Given this list of marker genes THAP2, OTUD4 (OTU deubiquitinase 4), CYTH3, ADAMTS3, SRI, PRKG1, TENT4B, MBOAT2, DNAJB5, DNAJB9, HIPK3, UBE2W, ZNF224, CFL2, ANKRD40, LIN7A, HS3ST3A1 (NCBI Gene Id 9955), SEC23A, ZC3H4, KHDRBS1, ATP5F1B, CNEP1R1, QKI, VAT1L, LBR, SGCE, RO60, LRP1, PPP1R18, PTBP3, PITPNM3, CBX4, MAPK7, CASZ1, PTPN14, MED13, GXYLT1, FEZ2, NOVA1, TOB1, RANBP9, HIPK1, STRADB, ULK2, KIF14, GABBR2, SECISBP2L, CHSY1, DENND5B, BNC2, NR3C1, IMMP2L, SCN5A, ZFX, AGFG1, PRDM16, DCBLD2, SLC25A36, XKR4, CBL, YPEL2, ELOC, TRMT9B, PIK3CA, BDP1, ELL2, RUSC2, ERRFI1 (ERBB receptor feedback inhibitor 1), SLC24A4, PTAR1, CLASP2, ARIH1, RBFOX2, HOOK1, TFAP2A, SDC2, GJC1, GOLGA7, GATA4, SLC4A7, ZC3H6, SLF2, RBFOX3, INSM2, RBSN, GSTA4, FRMD6, MBNL3, CDYL2, RGL1, BCL11B, ITGA1, RDH10, ADH1B, PI4K2B, PCDH19, NOVA2, ANKRD44, TMX4, BAP1, NAB1, TRIM23, MSL2, PSAT1, NAP1L5, YWHAB, FSCN1, HSPA13 (heat shock protein family A (Hsp70) member 13), PTPN21, ATAD2B, S100PBP, CEP97, TBK1, RAB21, SLC6A11, TRAPPC8 (trafficking protein particle complex subunit 8), ERG, MMD, SUZ12, EGLN1, PPHLN1, GPRASP2, ATXN1, PHTF2, GNAQ, TLCD5, CAMSAP2, ALDH1A1, TRHDE (NCBI Gene Id 29953), NTRK2, RND3, EDEM3 (ER degradation enhancing alpha-mannosidase like protein 3), PMAIP1, MAP4K4, SFXN1, ETS1, GIT2, NCOA2, OSBPL11 (oxysterol binding protein like 11), NCS1, PPP2R5E, TBC1D12, ZYG11B, FOXG1, FLII, CLIC4, SCAMP1, USP25, PLPP3, NUDT4, LRP1B, INTS8, CRTAP, TBCA, CYTH1, ADIPOR2, SMARCD1 (NCBI Gene Id 6602), SYNJ1, APOO, TOGARAM1, AP1S2, PTPN12, CPED1, CRH, LOX, ERICH4, OSTM1, DESI1, MARCKS, PHF21B, HS3ST1, RTKN2, CDK17, JAKMIP2, JCAD, B3GLCT, ATP11C, PRTG, HYCC2, PUM2, CCNJ, PIM2, ZMAT3, SLC1A2, ZFPM2, WASF3, EXD2, MPRIP, SLIT2, ZEB1, COPS8, VEGFA, GARRE1, THAP1, ELAVL2, MAP4K5, PAG1, PROK2, TMOD3, HDHD2 (NCBI Gene Id 84064), SLITRK1, RAB11FIP2, DCUN1D5, AMFR, TAF12, PPP4R2, GOLGA1, CEP350 (NCBI Gene Id 9857), NRG1, JAZF1, SLC30A7, ARID4B, SCD, NTF3, FN1, TSC22D2, TAP2, CORO1C, FOXN2, GPR158, RIMS2, CTDSPL2, SLC35E2B, SULF1, EIF4E2, PPM1F, DNAJC3, SCAI, PIKFYVE, NPC1, POLK, NEDD1, SPAG9, STRN, MINDY2, CHN2, DPY19L3, CCNYL1 (cyclin Y like 1), MIEF1, DPH6, PKIA, PPFIA1, GLI3, PPP2R1B, FARP1 (FERM, ARH/RhoGEF and pleckstrin domain protein 1), STK4, TMEM164, ARHGAP6, BLCAP (BLCAP apoptosis inducing factor), SYDE1 (synapse defective Rho GTPase homolog 1), NUFIP2, DLC1 (DLC1 Rho GTPase activating protein), CHRDL1 (chordin like 1), MOSMO, LHFPL6, RIC1, PCLAF, DNMT3B, DGKH, PICALM, PSIP1, SNX16, B3GNT2, ZNF131, HS2ST1, NPM1, TLN2, TMEM17, RASSF8, CCDC177, SERINC1, TBL1XR1, ARL2BP, CSNK1G3, KCTD8, TIMP2, NANOS1, SYVN1, PCMTD1 (NCBI Gene Id 115294), MARF1, WIPF1, CERT1, ZFTA, CAB39, TCAIM, NCK2, YWHAG, CCDC82, WNT16, VASH2, SRGAP1, FNDC3B, SLK, PRKACB, GAS2L3, PLXNC1, SCN8A, HMBOX1, CHRNA6, RRP15, CUX1, EPS8, KDR, TLN1 (talin 1), USP6NL, XKR8, RECK, CHRM2, PRDM1, MATR3, GTF3C4, JKAMP, POGLUT2, NOTCH1, KDM7A, SERPINI1, MARCHF6, CLASP1, HECTD2, CDYL, MAP3K1, SLC35B4, KRT80, FAT3, SNRPB2, ATL2, SESN3, CDH20, DIXDC1, GPR180, A1CF, RTF1, WWC3, CLIP1 (NCBI Gene Id 6249), MFAP5, FOXF1, DGKA, CSMD3, JUN, ZCCHC24, CLVS2, DACH1, MAPRE1, HMGB3, FSD1L, BICC1, KCNQ3, RDX, DZIP1, SLC6A1, SLC39A14, CEP41, ROCK2, KLF4, RPS6KB1, TMEFF2 (NCBI Gene Id 51753), REEP1, GTPBP10 (NCBI Gene Id 85865), FLI1 (Fli-1 proto-oncogene, ETS transcription factor), SLC35E2A, RASA2, ZNF532, GEM, ZKSCAN8, PI4KB, OCLN, IKZF2, HAPSTR1, ELMOD2, ZSWIM4, CNOT6, DTNA, MAP4K3, LEPR, MSN, ELK4, SEMA6D, WDR82, GPATCH8 (NCBI Gene Id 23131), SCRT2, SUSD5, IGF2R, ZEB2, CNOT9, NFIA, BLTP3A, SLC14A1, PTHLH, NR5A2, DNA2, MIB1, DPY19L1, CECR2, MBNL2, SESN1 (NCBI Gene Id 27244), ZBTB10, ZDHHC21, ARL5A, ZFAND6, HNRNPD, PDIK1L, HOOK3, PPM1E, PLCL1, MTF2, IER5, DENND1B, PPP1R9B, PTPRZ1, FSTL1, RIPK2, RNF2, DENND5A, ASAP1, RAP1B, EXOG, FBXO30, PHACTR3, WAPL, EVI5, TRIM33, ENO4, PPM1B, CNTN1, PGM2L1, FAM118B, FBXO33, RNF19A, MPDZ, PLPPR4, KYNU, FAM8A1, WASF1 (WASP family member 1), CASR, AFF3, PKD1, SEMA3F, MEX3D, UBE2R2, NECTIN4, ESRRG, ZBTB38, FAM227B, RPS6KA3, BRWD3, DDIT4L, KLF6, VLDLR, IGSF10, TUBB, PDS5B, ZNF217, NBR1 (NCBI Gene Id 9740), PABIR3, VASH1, USP27X, ANK3, FIGNL2, HDAC9, MYZAP, KANK2, AKAP7, SGIP1, NRBP1, PPP1R9A, FHL1, CRKL, ZNF326, KCND2, FERMT2, SOX2, NOG, B4GAT1, CKAP4, ARHGAP20 (NCBI Gene Id 57569), FIGN, DUSP1, RAP2C, ELK3, C11orf87 (chromosome 11 open reading frame 87), TBX18, IPO7, GPM6A, PHEX, MGAT2, GLCCI1, EIF2B5, LRRC8A, SIX1, CNKSR3, PPP1R10, SBSPON, FBXW7, MYB, MAP2, ZNF711, MCFD2, CCNE2, TSSK1B, RANBP10, CEP85L, TSC22D1, here is a description of the gene set: Human Gene Set: MIR200B_3P species: Homo sapiens from publication Chen Y, Wang X (PMID 31504780) Genes predicted to be targets of miRBase v22 microRNA hsa-miR-200b-3p in miRDB v6.0 with MirTarget v4 prediction scores > 80 (high confidence targets).